The following is a description of a gene set: Human Gene Set: TRAVAGLINI_LUNG_CD8_MEMORY_EFFECTOR_T_CELL from publication Travaglini KJ, Nabhan AN, Penland L, Sinha R, Gillich A, Sit RV, Chang S, Conley SD, Mori Y, Seita J, Berry GJ, Shrager JB, Metzger RJ, Kuo CS, Neff N, Weissman IL, Quake SR, Krasnow MA (PMID 33208946) species: Homo sapiens, and this is the list of marker genes: LINC00861, CD8B, CXCR6, IKZF3, RPL31, DUSP2, SYNE2, CDC42SE2, CD3G, CD3D, IL32, RPS14, CD8A, RPS27, IL7R, PIP4K2A, RPL23A, CMC1, SH2D1A (SH2 domain containing 1A), RPL30, MALAT1, GZMK, CCL5, RPS25, TC2N, PYHIN1, RPS29, FYN, PRDM1